The following is a description of a gene set: Amplified CCND1 to cell cycle G1/S. Pathway ID: N00275. Pathway type: Variant. Pathway class: nt06270 Breast cancer. Human Gene Set: KEGG_MEDICUS_VARIANT_AMPLIFIED_CCND1_TO_CELL_CYCLE_G1_S Pathway Definition from KEGG: (CCND1*+CDK4) -> RB1 // E2F studied in species Homo sapiens, and this is the list of marker genes: E2F2, E2F3, RB1, E2F1 (NCBI Gene Id 1869), CCND1 (cyclin D1), CDK4